Given this list of marker genes GREB1, PHIP, UBR3, TMTC4, WDR7, REST, OBSL1, RIOK2, VPS4B, PPP1R10, TP63, NUP58, INTS6L, GLRX2, DLK1, NRG1, DPYSL3, FAM13B, STUM, LAMP2, SCARA3, CTNNA2, ODAPH, YME1L1, ZNF268, PINX1, DENND11, C16orf87, SLC5A12, HPS1, VEZF1, TSHZ3, SLC7A14 (solute carrier family 7 member 14), VPS26A, ABTB3, CNPY2, PAX5, ETV5, ADH6, MIER3, TNRC6C, CASP7, ZNF461, CDRT4, MLLT10, EIF4H, ZFP82, MYH3, PCDH9, TRDN, ZNF440, SH3BGRL2, FUT8, RGS4, B3GALNT1, ATP11A, CNIH1, KCNE3, CD209, ZCCHC10 (NCBI Gene Id 54819), SGCZ, CPEB2, PI15, OSBPL10, TVP23C-CDRT4, MTMR4, ADNP, ZNF559, B3GALT2, RBPJ, ZFAND6, LSM14B, SGCB, CLNK, IL17RB, MBLAC2, KCMF1, GCLC, ABR, IFRD1, WDR44, CALN1, NRCAM, USP46, ZNF681, FBXO43, EPC2, NR3C1, CCL16, RGL2, YWHAH, ZNF570, HDX, PAK5, CYSLTR1 (NCBI Gene Id 10800), LTBR, KCNJ3, SLC22A10, ZNF503, MED1, AQP4, MASTL, CLIC2, NR2C2, MCOLN3, SLC25A15, NAA30, SLC7A11, TMEM47, SEC63, PSMA8, BEAN1, SAMD4A, NDUFA12, MMP8, SH3TC2, ARHGAP6, CAMTA1, EP300, TGFBR1, FGG, ZEB2, CERT1, IGF2, SP4, PGBD2, here is a description of the gene set: Human Gene Set: MIR4666B from publication Chen Y, Wang X (PMID 31504780) Genes predicted to be targets of miRBase v22 microRNA hsa-miR-4666b in miRDB v6.0 with MirTarget v4 prediction scores > 80 (high confidence targets). species: Homo sapiens